The following is a description of a gene set: Genes down-regulated in KLRG1- SELL low T reg: CD69- versus CD69+. Thymic-derived natural T regulatory cells (nTregs) are characterized by functional and phenotypic heterogeneity. Recently, a small fraction of peripheral Tregs have been shown to express Klrg1, but it remains unclear the extent Klrg1 defines a unique Treg subset. Here we show that Klrg1+ Tregs represent a terminally differentiated Treg subset derived from Klrg1- Tregs. This subset is a recent antigen-responsive and a highly activated short-lived Treg population that expresses enhanced levels of Treg suppressive molecules and that preferentially resides within mucosal tissues. The development of Klrg1+ Tregs also requires extensive IL-2R signaling. This activity represents a distinct function for IL-2, independent from its contribution to Treg homeostasis and competitive fitness. These and other properties are analogous to terminally differentiated short-lived CD8+ T effector cells. Our findings suggest that an important pathway driving antigen-activated conventional T lymphocytes also operates for Tregs. Gene expression analysis was performed of this and other Treg subsets based on expression of CD62L, CD69, and Klrg1 to define the molecular properties of Klrg1+ Tregs and its relationship to other Treg subsets found in the peripheral immune tissues. from publication Cheng G, Yuan X, Tsai MS, Podack ER, Yu A, Malek TR (PMID 22786769) Human Gene Set: GSE36527_CD69_NEG_VS_POS_TREG_CD62L_LOS_KLRG1_NEG_DN studied in species Homo sapiens, and this is the list of marker genes: SPESP1, KCTD2, COTL1, NELFB, DUS1L, ATP6V0D1, NISCH, UBE2V1, LFNG, STK11, ZNF740, SIGIRR, RHOG, TMEM115, RCN3, GRAMD1A, CCDC12, RHEBL1, TSNAX, PABPC4, OTULINL, COG8, ATP6V0A2, CXCR3, HEXIM1 (NCBI Gene Id 10614), WASF2, PSEN2, MNT, TNFAIP8L1, EIF2AK3 (NCBI Gene Id 9451), RPP25L, UBAP1, SLC29A1, ZBTB48 (NCBI Gene Id 3104), SLC15A4, ANAPC11, DDX21, SMARCD2, RHOT2, ZNF593, C5orf34, CNPPD1, NME4, TRIM39, ZNF212, FOXJ3, ACADVL, REPS1, TUT1, PRKAB1, CORO1B, PABPN1, SLA2, NUDT16L1, FAM89B, EIF3F, TUBA3C, PPP6C, CNR2, ID3, SLF2, JAK1, EMC3, DCAF15, ZFYVE19, PLAUR, TP53BP1, HGSNAT, BOLA1, TPRKB, CCL25, RPA1, TPRA1, MAF1, NUP62, TBCC, SH2B1, CALU, LCMT2, ZNF764, ABCD4, TRAF4, PYCR2, ELF2, CHST12, CRYL1, SNRPA, CYTH2, EIF4B, GLCE, GNB2, MOB2, CTDSP2, SKI, POR, RNPEP, PPM1G, RAMP3, RANBP10, TMEM160, CRISP2, BCL7C, ERCC3 (ERCC excision repair 3, TFIIH core complex helicase subunit), MMD, LLGL2, PHF23, B4GALT7, SLC20A1, CTSW, OTULIN, COMMD4, RNF6, STAT6, CKMT2, CDC34, IER5L, PITPNM1, MAN2B1, ING4, RAB40C, DIPK2A, NAA60, FCGRT, CRIP1, COPG1, AKNA, UCK1, IL16, FBXO22, KCNN4, RASSF5, MCCC1, STAT5B, CDC42SE1, GUK1, SPN, WDR4, SRF, SESN1, VSIR, PGP, EIF3L, TBC1D10B, WDR45B, ANKRA2 (ankyrin repeat family A member 2), WIPI2, CLCF1, DICER1, STX5, NGRN, APPBP2, ZNF707, IZUMO1R, SPOCK2, PKP3, ACVR2B, MKNK2, SERP1, VAMP1, TPRG1L, ALKBH4, SPSB3, YRDC, TAF5L, ZFAND2B, RNF5, NXF1, PITHD1, CHKB, THAP12, PRPF6, TMEM222, TNIP1, ATP5F1A, RRP1, FBXO32, MRI1, MEDAG, S1PR4, GNA11, FBXL3, E4F1, SNX20, NR4A1, GFUS, IFRD2, PDXK, CDKN2D, MLST8, COQ8A, TNFAIP1, ECSIT, SLX9, PPP4R3A, CDK11B, TNFRSF1B, FBXO45, EIF3D, DNAJB1, DDIT3